The following is a description of a gene set: Human Gene Set: HP_CEREBELLAR_VERMIS_ATROPHY Wasting (atrophy) of the vermis of cerebellum. species: Homo sapiens Cerebellar vermis atrophy, and this is the list of marker genes: TDP1, SCO2, PEX16, WWOX, XRCC4, DLG4, COX20, ATXN8OS, GTPBP2, CACNA1A, SACS, BCL11A, PEX2, DAB1, QARS1, PRKCG, CACNA1G, ENSG00000288330, SEPSECS, CAPN1 (NCBI Gene Id 823), FA2H (NCBI Gene Id 79152, fatty acid 2-hydroxylase), ARF1, CNTNAP2, WDR4, COG3, PMPCA, TAF4, SCYL1, PNPLA6, TMEM240, SETX, CACNA2D2, CHP1, POLR3B, STXBP1, RFC1, HTT (huntingtin), NPTX1, VPS41, LMX1B, CHD8, PIK3R5, OPA1, SLC9A1, KIF1A, MARS2, TRPC3, GJB1, SYT14, ELOVL5, FAR1, SLC39A8, PLP1, MME, CUL4B, ADPRS, GRID2, ITPR1, TUBB, RNU12, PIGS